Given this list of marker genes PARP1, TRAFD1, NLRX1, SAMHD1 (SAM and HD domain containing deoxynucleoside triphosphate triphosphohydrolase 1), CEP63, HLA-B, HLA-F, DDX39A, PARP14, DNAJA3, LILRB1, NECTIN4, STAT2, ATG12, METTL3, TGFB1, SFN, ATG5, TREX1, YTHDF2, CD96, A2M, NMI (N-myc and STAT interactor), NLRC3, IFI16, KIR2DL4, GIGYF2 (NCBI Gene Id 59281), OAS3, INPP5D, INS, NLRP4, HLA-A, PTPN2, MUL1, SERPING1, LYAR, MICA, PTPN6, TTLL12, CEACAM1, YTHDF3, DTX4, MIR181B1, LGALS9, RPS19, CNOT7, NR1H3, HLA-G, ARG1 (arginase 1), TRIM21, TIGIT, SERPINB4, DRD2, OTOP1, ARRB2, ZDHHC18, ADAR, MIR4691, CR1, USP18, PIM1, DUSP10, USP38, SMIM30, ISG15, IRAK3, SLAMF8 (SLAM family member 8), KLRD1, TYRO3, CACTIN, EIF4E2 (NCBI Gene Id 9470), USP15, KLRC1, PVR, AURKB, YWHAZ, SERPINB9, FAM3A, MMP12, SUSD4, VSIG4, CRK, OAS1, BANF1, CLEC12B, GRN, NLRC5, GRB2, HLA-E, DCST1, NECTIN2, DHX58, PPARG, HAVCR2, NR1H2, TNFAIP3, ACOD1, MIR21, here is a description of the gene set: Human Gene Set: GOBP_NEGATIVE_REGULATION_OF_INNATE_IMMUNE_RESPONSE Any process that stops, prevents, or reduces the frequency, rate or extent of the innate immune response. studied in species Homo sapiens